The following is a description of a gene set: species: Homo sapiens Human Gene Set: chr14q13, and this is the list of marker genes: NKX2-1-AS1, PSMA6, PRORP, PHKBP2, KRT18P6, SRP54, NFKBIA, BRMS1L, NUTF2P2, SLC25A21, NKX2-1, SRP54-AS1, RPL23AP8, SFTA3, INSM2, ILF2P2, RPL7AP3, MBIP, SLC25A21-AS1, RPS19P3, EGLN3-AS1, BAZ1A-AS1, MIR4503, RN7SKP21, RPL29P3, QRSL1P3, MIPOL1, RPL23AP70, DPPA3P2, NPAS3, BAZ1A, RPL9P3, SPTSSA, IGBP1P1, FAM177A1, EAPP, RNU7-41P, RALGAPA1, RPL23AP71, ENSG00000303346, RN7SKP257, SNX6, CFL2, MRPL57P8, ENSG00000258661, DNAJC8P1, RNU6-1261P, EGLN3, RPLP0P3, NKX2-8, PAX9, RPL12P6, PPP2R3C, DPRXP3, RNU1-28P, RNU1-27P (NCBI Gene Id 26867), RNU7-93P, SEPTIN7P1, LINC00609, RPS3AP4, RNU6-273P, PTCSC3